Given this list of marker genes Kctd1, Baalc, Vtcn1, Kif14, Ptprr, Zfp740, Gxylt1, Tnfaip8, Prep, Ccr3, Crim1, Nup98, Ago1, Or10d5j (olfactory receptor family 10 subfamily D member 5J), Slc44a1, Thbs1, Nampt, Cxcr6, Ica1l, Rab1a, Arhgap36, Nt5e, Calb1, Nrbf2, Mapk6, Vstm5, Brwd1, Fkbp1a, Zkscan17, Gps1, Zfp346, Runx1t1, Tmem178b, Creb1, Slitrk4, Sox6, Nme6, Fchsd2, Adgrb3, Flnb, Jmy, Clk4, Top1, Zbtb10, Plekhg6, Arl10, Frmd5 (NCBI Gene Id 97040), Kcna6, Ankfn1, Igdcc3 (immunoglobulin superfamily, DCC subclass, member 3), Sidt1, Col18a1, Canx, Cpeb2, Mpz, Adamts12, Dennd2b, Smyd4, here is a description of the gene set: from publication Chen Y, Wang X (PMID 31504780) studied in species Mus musculus Mouse Gene Set: MIR_327 Genes predicted to be targets of miRBase v22 microRNA mmu_miR_327 in miRDB v6.0 with MirTarget v4 prediction scores > 80 (high confidence targets).